The following is a description of a gene set: The cell differentiation process that results in commitment of a cell to become part of the mesoderm. Mouse Gene Set: GOBP_MESODERMAL_CELL_FATE_COMMITMENT species: Mus musculus, and this is the list of marker genes: Nodal, Six2, Foxc2, Tbx6, Bmp4 (bone morphogenetic protein 4), Mesp1, Hoxa11 (homeobox A11), Wnt3a, Pax2, Bmpr1a, Fgfr1, Sfrp2, Nanog, Dkk1, Etv2, Pou5f1, Eya1, Smad1